The following is a description of a gene set: Human Gene Set: GOBP_REGULATION_OF_CHOLESTEROL_STORAGE Any process that modulates the rate or extent of cholesterol storage. Cholesterol storage is the accumulation and maintenance in cells or tissues of cholesterol, cholest-5-en-3 beta-ol, the principal sterol of vertebrates and the precursor of many steroids, including bile acids and steroid hormones. species: Homo sapiens, and this is the list of marker genes: NR1H2, CES1, ABCG1, MSR1, ABCA1, LPL, MIR144, SREBF2, PPARG, TTC39B, PPARD, CD36, TREM2, APOB, MIR146A, PPARA, SCARB1, EHD1, NR1H3